The following is a description of a gene set: Any microtubule that is part of a mitotic or meiotic spindle; anchored at one spindle pole. species: Homo sapiens Human Gene Set: GOCC_SPINDLE_MICROTUBULE, and this is the list of marker genes: KLHL22, KNTC1, ARL3, HAUS1, CHMP4B, CLASP1, CHMP2B, CHMP6, CHMP3, MAPRE1, BOD1, PLK1, KIF2A, HAUS6, ZWILCH, AURKB, KLHL21, AURKC (NCBI Gene Id 6795), RAB11A, EML3, TUBGCP3, POLB, MISP, CCSAP, CHMP1A, PSRC1, SKA3, CHMP4BP1, KIF18B, PRC1, HAUS7, HAUS8, CHMP4A, CALM2 (NCBI Gene Id 805), RMDN1, FAM110A, CHMP5, CENPE, KIF11, CALM3, SKA1, TUBG2, CSNK1D, PARP4, KIF18A, CLASP2, KIF3A, AURKA, PAFAH1B1, ZW10, HNRNPU, HAUS5, HAUS4, FAM161A, HAUS2, KIF3B, CHMP1B, HAUS3, BBLN, CAPN6, TUBG1, BIRC5, CDK1, KIFAP3, MTCL1, CCDC57, CLTC, NUMA1, SKA2 (NCBI Gene Id 348235), MAP1S (microtubule associated protein 1S), KIF4A, CUL3, DYNLT3 (dynein light chain Tctex-type 3), CEP295, RMDN2, CHMP4C, MAPRE3, CALM1, CHMP2A, TTL, CHMP7, MAP9, RMDN3